The following is a description of a gene set: Mutation-caused aberrant Htt to transport of calcium. Pathway ID: N00987. Pathway type: Variant. Pathway class: nt06461 Huntington disease. Pathway Definition from KEGG: HTT* // DLG4 -> NMDAR -> Ca2+ -- MCU -> Ca2+(mito) -- MPTP -> CYCS == APAF1 -> CASP9 -> CASP3 species: Homo sapiens Human Gene Set: KEGG_MEDICUS_VARIANT_MUTATION_CAUSED_ABERRANT_HTT_TO_TRANSPORT_OF_CALCIUM, and this is the list of marker genes: GRIN1, SLC25A5, DLG4, GRIN2A, CASP3, VDAC3, VDAC2 (NCBI Gene Id 7417), HTT, APAF1, GRIN2C, SLC25A31, MCU, GRIN2B, GRIN2D, CYCS, CASP9, SLC25A4, SLC25A6, VDAC1